The following is a description of a gene set: Mouse Gene Set: GOBP_NEGATIVE_REGULATION_OF_CELL_DIVISION species: Mus musculus Any process that stops, prevents, or reduces the frequency, rate or extent of cell division., and this is the list of marker genes: Intu, Ptch1, Aspm, Bmyc, Vps4a, E2f8, Gpr15lg, E2f7, Blm, Zfyve19, Txnip, Myc, Tex14, Susd2, Chmp4c, Aurkb